Given this list of marker genes Tgfbr2, Tgfb2, Tgfbr1, Tgfb1, Eng, Tgfb3, here is a description of the gene set: studied in species Mus musculus Mouse Gene Set: GOBP_REGULATION_OF_EPITHELIAL_TO_MESENCHYMAL_TRANSITION_INVOLVED_IN_ENDOCARDIAL_CUSHION_FORMATION Any process that modulates the frequency, rate or extent of epithelial to mesenchymal transition involved in endocardial cushion formation.